The following is a description of a gene set: species: Homo sapiens CD3-positive T cells were negatively isolated from 10 SLE patients and 9 healthy controls without SLE. All of the SLE samples and control samples were compared with one another to identify baseline differences in expression due to the disease. Next, T cell preparations from 4 of the control subjects were stimulated with either Nitric Oxide (NOC-18) 600 uM for 24hr or stimulated through CD3/CD28 for 24hr to determine which genes were responsive to these signaling mechanisms. Here, we show that activity of the mammalian target of rapamycin (mTOR), which is a sensor of the mitochondrial transmembrane potential, is increased in SLE T cells. Activation of mTOR was inducible by NO, a key trigger of MHP which in turn enhanced the expression of HRES-1/Rab4, a small GTPase that regulates recycling of surface receptors through early endosomes. Expression of HRES-1/Rab4 was increased in SLE T cells and, in accordance with its dominant impact on the endocytic recycling of CD4, it was inversely correlated with diminished CD4 expression. HRES-1/Rab4 over-expression was also inversely correlated with diminished TCRζ protein levels. Combined with follow up studies, these results suggest that activation of mTOR causes the loss of TCRζ in lupus T cells through HRES-1/Rab4-dependent lysosomal degradation. Human Gene Set: GSE13887_RESTING_VS_ACT_CD4_TCELL_UP Genes up-regulated in CD4 T cells from healthy donors: resting versus activated by anti-CD3 and anti-CD28. from publication Fernandez DR, Telarico T, Bonilla E, Li Q, Banerjee S, Middleton FA, Phillips PE, Crow MK, Oess S, Muller-Esterl W, Perl A (PMID 19201859), and this is the list of marker genes: CEP250, PIGT, TAF3, NFATC2 (NCBI Gene Id 4773), NEIL2, MIR499A, RAPGEF5, IL1A, ATXN1L, PRSS58, CRYBA1, CD48, UGDH, TCF23 (transcription factor 23), CETN1, AMIGO3, PRSS33, FZD3, COL6A4P1, FTO, KRTAP3-3, RSPO1, CFAP70, PKHD1, DYNC1H1, DNAJC24, RNASE10, EPPK1, LCT, GTF3C1, CD109, POLR1A, MINAR1 (NCBI Gene Id 23251), ATP8B2, TMEFF2, SLC39A9, KCNT1, PRRC2B, SEC14L4, MOCS3, SPRR3 (NCBI Gene Id 6707), BRAP, MIR129-2 (NCBI Gene Id 406918), SSX9P, NFYC, DNASE1, ACVR1C, ZNF276, PANX3, IDO1, CES3, PRRC2A, ANTXRL, MRAS, GATAD2B, CAVIN1, ITIH2, SLC34A3, OAZ3, KIR3DL2, SLC45A3, MIR183, SLAMF9, MRAP2 (melanocortin 2 receptor accessory protein 2), LHX8, RCVRN, TANGO6, EFCAB10, PON2, HYAL6P, ME1, HTR5BP, CCL8, GJB5, ADARB2, TTC23L, FAM149A, RTL6, MRPS35, DDR2, CER1, AQP1, MMP9, SOD3, C2CD6, SEMG1, CALHM5, HEBP1, PSME1, TAAR1, SIX4, DNTTIP1, PCNX3, LRRC2, PIK3C3, HOXB3, KDM4B, STOX1, ANK1, PDE6G, COLGALT2, TPH2, NPY2R, MICAL2, SERPINB12, ZC3H4, SERPINB11, CYFIP2